The following is a description of a gene set: Human Gene Set: REACTOME_METALLOPROTEASE_DUBS species: Homo sapiens Metalloprotease DUBs, and this is the list of marker genes: BRCA1, H2AC1, H2AC13, H2AC15, EP300, UBC, BABAM1, BRCC3, H2AC6, STAMBP, H2AC17, ABRAXAS2, UBB, H2AC8, NLRP3 (NLR family pyrin domain containing 3), H2AC12, H2AC21, RPS27A, H2AC16, H2AC4, MYSM1 (NCBI Gene Id 114803), STAM, H2AC11, H2AC25, UIMC1, BABAM2, H2AC18, H2AC14, PSMD14, KAT2B, STAMBPL1, UBA52, ABRAXAS1, H2AC7, H2AC20, BARD1 (BRCA1 associated RING domain 1), H2AC19